The following is a description of a gene set: from publication Yevshin I, Sharipov R, Kolmykov S, Kondrakhin Y, Kolpakov F (PMID 30445619) Genes containing one or more binding sites for (ZNF354C) in their promoter regions (TSS -1000,+100 bp) as identified by GTRD version 20.06 ChIP-seq harmonization. Human Gene Set: ZNF354C_TARGET_GENES species: Homo sapiens, and this is the list of marker genes: STAT6, NOL6, STX4 (NCBI Gene Id 6810), LUZP1, CROCCP3, RRN3P1, HEBP2, RPL36, SDC4, SNHG30, ITGAL-AS1, WNT8A, LINC00431, HAPLN2, CWC25